Given this list of marker genes MECP2, FBP1, CASK, SYT1, CNTNAP2, TCF4, here is a description of the gene set: species: Homo sapiens Intermittent hyperventilation Episodic hyperventilation. Human Gene Set: HP_INTERMITTENT_HYPERVENTILATION